The following is a description of a gene set: An assembly of four or five subunits which form a structure with an extracellular N-terminus and a large loop that together form the ligand binding domain. The C-terminus is intracellular. The ionotropic glutamate receptor complex itself acts as a ligand gated ion channel; on binding glutamate, charged ions pass through a channel in the center of the receptor complex. NMDA receptors are composed of assemblies of NR1 subunits (Figure 3) and NR2 subunits, which can be one of four separate gene products (NR2A-D). Expression of both subunits are required to form functional channels. The glutamate binding domain is formed at the junction of NR1 and NR2 subunits. NMDA receptors are permeable to calcium ions as well as being permeable to other ions. Thus NMDA receptor activation leads to a calcium influx into the post-synaptic cells, a signal thought to be crucial for the induction of NMDA-receptor dependent LTP and LTD. species: Homo sapiens Human Gene Set: GOCC_NMDA_SELECTIVE_GLUTAMATE_RECEPTOR_COMPLEX, and this is the list of marker genes: EPS8, PTK2B, GRIN1 (glutamate ionotropic receptor NMDA type subunit 1), GRIN3B, GRIN2D, GRIN2C, GRIN2A, GRIN2B, GRIN3A